The following is a description of a gene set: Genes down-regulated in comparison of wild type macrophage treated with LPS (TLR4 agonist) at 4 h versus those from IRAK4 deficient mice treated with LPS (TLR4 agonist) at 4 h. Human Gene Set: GSE9037_WT_VS_IRAK4_KO_LPS_4H_STIM_BMDM_DN species: Homo sapiens IRAK-4 is an essential component of the signal transduction complex downstream of the IL-1- and Toll-like receptors. Though regarded as the first kinase in the signaling cascade, the role of IRAK-4 kinase activity versus its scaffold function is still controversial. In order to investigate the role of IRAK-4 kinase function in vivo, ‘knock-in’ mice were generated by replacing the wild type IRAK-4 gene with a mutant gene encoding kinase deficient IRAK-4 protein (IRAK-4 KD). Analysis of bone marrow macrophages obtained from WT and IRAK-4 KD mice with a number of experimental techniques demonstrated that the IRAK-4 KD cells greatly lack responsiveness to stimulation with the Toll-like receptor 4 (TLR4) agonist LPS. One of the techniques used, microarray analysis, identified IRAK-4 kinase-dependent LPS response genes and revealed that the induction of LPS-responsive mRNAs was largely ablated in IRAK-4 KD cells. In summary, our results suggest that IRAK-4 kinase activity plays a critical role in TLR4-mediated induction of inflammatory responses. from publication Koziczak-Holbro M, Glück A, Tschopp C, Mathison JC, Gram H (PMID 18266302), and this is the list of marker genes: SH3BP2, MCM7, TBCCD1, CDT1, PAX7, APOBEC1, VWF, C3AR1, NKX6-2, AP3M2, ARL4C, EFEMP1, KCNK13, GDF5, MXD4, FUT11, SATB1, H2AJ, IRF7, CLUAP1, NDUFA7, DUT, APRT (NCBI Gene Id 353), ARHGEF7, CDCP1, TRIM8 (tripartite motif containing 8), LPL, RAB8A, PTPRS, AAGAB, GMFG (glia maturation factor gamma), PIGZ, TTC21B, ACSF2, CMIP, AP2A2, HELB, NGEF, TESC, CCNA2, PAG1, SPP1, ANXA6, MCEE, PRRC1, CHID1, CAMK2G, NRP1, SIKE1 (suppressor of IKBKE 1), CERS5, PCLAF, BLNK, SH3BGRL3, VSIR, HCN3, ZBTB14, BCL2L1, TOM1L2, MYO1E, ANLN (anillin, actin binding protein), PDYN, BRCA1, CMC1, GHRHR, MAPK9, OPRM1, ITFG1, CST3 (NCBI Gene Id 1471), NCOA2, LDLRAP1, HSPH1, BTC, NSD1 (nuclear receptor binding SET domain protein 1), UBE2C, PPM1H, COPZ2, RFWD3, CCDC3, SMIM15, PGGHG, ACE, IL5, POLE, ILRUN, GIMAP7, RPA1, CSRNP2, DAP, CDC42SE1, RSPH3, ALG2, GPR173, OXT, ITGA8, DHRS1, SPATA19, RPS3A, DDI2, SNX30, BLVRA, TWF1, VLDLR, FNIP2, FYTTD1, CACUL1, ENTREP1, FAM13C, RARRES1 (NCBI Gene Id 5918), SKA2, MAP3K1, RAMP1, PUS7, FLI1, NUDT16, ATP8B3 (NCBI Gene Id 57203), ABCD3, TCF7L2, FOXK2, PLP1, RAB21, POLD1, VHL, PLA2G6, SURF1, DOK1 (NCBI Gene Id 1796), MFSD12, TUBA1A, NPTX1, IMPG1, TXNIP, RPS27, TGFB2, MSRB3, ARHGAP25, EPHB2, MKRN3, CEP55, GATAD1, SARAF, TUBA1B, NR2F1, CDK1, APLP2, TSPAN11, TSPAN17, BHMT2, EID1 (EP300 interacting inhibitor of differentiation 1), TPM2, CASP3, KLF10, MRPL30, RPE, GINS4, CORO1C, ARL15, TBC1D22A, FADS2, BMP1, IGSF11, RCBTB2, SHISA4, PLPP1, BLVRB, GLG1, NFATC2, AIF1, RIC8A, CDIN1, AQP6, SLC4A1, NXNL2, FABP7, MAP3K3, OSBPL6, MPV17, CCR5, LIME1, RFC1, TGIF2, CMA1, TBC1D14, MIF, MBLAC2, PATZ1, S100A8, MCAM, CCDC102A, FLRT2, CKB, BMP4, LBR, SMAGP, TSKS, VRK2, IFITM3, PTPRCAP, TRAPPC2L, DNAJC22, SMIM19, RASSF2